The following is a description of a gene set: Human Gene Set: REACTOME_SPHINGOLIPID_CATABOLISM studied in species Homo sapiens Sphingolipid catabolism, and this is the list of marker genes: PLPP3, ALDH3A2, SGPP2, PLPP1, SGPP1, ACER3, ACER2, ALDH3B1, ALDH3B2, SGPL1, ACER1, PLPP2